The following is a description of a gene set: studied in species Homo sapiens Genes having at least one occurrence of the highly conserved motif M35 GCANCTGNY in the regions spanning 4 kb centered on their transcription starting sites. This matches the MYOD1 transcription factor binding site V$MYOD_Q6 (v7.4 TRANSFAC). from publication Xie X, Lu J, Kulbokas EJ, Golub TR, Mootha V, Lindblad-Toh K, Lander ES, Kellis M (PMID 15735639) Human Gene Set: GCANCTGNY_MYOD_Q6 Comprehensive identification of all functional elements encoded in the human genome is a fundamental need in biomedical research. Here, we present a comparative analysis of the human, mouse, rat and dog genomes to create a systematic catalogue of common regulatory motifs in promoters and 3' untranslated regions (3' UTRs). The promoter analysis yields 174 candidate motifs, including most previously known transcription-factor binding sites and 105 new motifs. The 3'-UTR analysis yields 106 motifs likely to be involved in post-transcriptional regulation. Nearly one-half are associated with microRNAs (miRNAs), leading to the discovery of many new miRNA genes and their likely target genes. Our results suggest that previous estimates of the number of human miRNA genes were low, and that miRNAs regulate at least 20% of human genes. The overall results provide a systematic view of gene regulation in the human, which will be refined as additional mammalian genomes become available., and this is the list of marker genes: ERP27, DOK7, NDUFB8, NRAS, DMPK, AGBL5, MLLT6, GATA2, TUBB2B, PCGF1, SYT6 (NCBI Gene Id 148281, synaptotagmin 6), CNFN, GALR1, LYL1, GUCY1A1, PDAP1, ANGPTL7, MYT1, ARHGAP36, CDK2AP2, RAB6A, MSS51, MXD4, SHISA7, L3MBTL2, SOX5, RUNX1T1, ELL3, CAMKV, CDH10, MYO19, CACNB1, SDHAF2, MBNL2, EXOC5, LNX1, ANP32A, USP54, CHRNE, MORC4, GRK5, CPSF7, ATP2A2, NTRK3, REPS2, TBCC, KIRREL2, CCDC148, RRAD, GPR37L1, YPEL1, TIGAR, POU2F1, CLDN15, XPO1, ATP5F1B, EGLN1, DES, GRHL3, IRX5, CAMK1D, CASK, HNRNPDL, RHBDF2, SLC9A7, NEURL1, ZMIZ1, MUSK, ETF1, KNCN, NEUROD1, S100A8, GGNBP2, SPINK5, SOX2, CSNK2A2, CD72, NRXN2, TBL1Y, ALK, CASKIN2, PLPP7, OXR1, NHSL2, COBL, BNC2 (NCBI Gene Id 54796), YWHAE, HSD3B7, GAPDH, SPATC1L, AMMECR1, NOL9, FRMD4A, SLC29A4, CACNA2D3, NKAIN2, VWA5A, PHACTR3, ATXN7L2, CYLD, FBLIM1, GFRA1, TPM2, CCNE2, PEG10 (paternally expressed 10), TXLNG, TPMT, IGFBP5, IKZF2, EHD1, PRKCB, WNK2 (NCBI Gene Id 65268), CADPS, LDB1, NR4A2, ENPP5, TNFRSF21, HLA-DRB5, NEDD4L, TNMD, SMAP2, NLGN2, SUPT16H, EGR2, LHX3, EZH2, ABCB9, HSPA5, HOXA2, LURAP1L, MYO18A, FA2H (fatty acid 2-hydroxylase), NEUROD6, PPP2R3A, HSP90AB1, TEAD2, DLL3, POFUT1, SH3BGRL3, MYCBP, POLD4, SEZ6, FITM1, OR2L13, HSALR1, ELAVL3, PLN, LAMA5, DRP2, NTN4, FSCN2, ZNF593, CHRD, UNC45B, DUSP4, LHFPL2, CD2AP (CD2 associated protein), TFAP2C, TJAP1, GIGYF2, DCHS2 (NCBI Gene Id 54798), KRT19, DMXL1, FGF12, TNNI2, HSPB6, PRR7, TRIM23, SLC43A3, ZMAT3, MAGI1, DAB2IP, SPEG, SYNRG, SNTB2, EFNA1, ITGB4, MORF4L2, CYFIP2, SOX15, FZD9, SRPK2, LRRN1, TSPAN9, DDIT4L, CDKN1B, EIF4G2, PTCHD1, PDE1A, ZNF503, RNF13, LDB3 (LIM domain binding 3), NOTCH1, CBFA2T3, ZFHX3, KLHDC7A, EDC4, KLHL41, ACTN3, KCNJ2, LINC01565, PPP2R5B, STRN3 (NCBI Gene Id 29971), MYCT1, TAS1R1, SIM2, ELP4, TNFRSF17 (NCBI Gene Id 608), RAPSN, TGIF1, SERF2, LRRTM3, E2F1, TEC, TRIR, RPS18 (NCBI Gene Id 6222), ITGB1BP2, BCAS4, STIM1, USP15, CRCT1, IGFBP3 (insulin like growth factor binding protein 3), XPO7 (NCBI Gene Id 23039), SPINT2, NAGLU, PPARGC1B, FOSL2, EML5, GABRA3, RNF19B (ring finger protein 19B), PDGFB, LORICRIN, NECTIN4, NPEPPS, CRIP2, KIF7, MEF2D, CLCN3, ANGPT1, MYL11, UBE2D3 (ubiquitin conjugating enzyme E2 D3), TMEM109, TACC1, IGFBP6, DBNDD1, NOL4, GATA3, ARMC8, ZNF205, GGN, ADAM11, PCDH12, AP5M1, STX5, SMARCA5, SPCS1, WNT6, KMT2E, SQLE, HOXD3, RNF220, SULT2B1, WDR47, JADE1, NDNF, CCDC177, VPS52, CAMKK1, KMT2A, CCND2, MCHR1, HTR2C, SREBF2, ZBTB16, RIN1, TSEN54, DNAJC17, CRELD1, HCRTR1, MT1E, GIT1, VAMP1, PCSK4, ODC1, HESX1, TJP1, PPP1CA, SYTL2, DNHD1, ZEB1, MLYCD, KCNQ1DN, ACVR1, PKP4, ELAVL2, FOS, AP4S1, PPP3CB, WWC1, CNTN6, TNNI1, COL4A3 (NCBI Gene Id 200750), SPEM1, TRAPPC13, GNG8, OVOL1, AARSD1, RBFOX1, HJV, METTL8, ADGRL3, EMX1, PCBP4, NGF, MRPS6, YPEL4, ROCK1, CITED2, FRMD6, CELF4, TMBIM1, EP300, DALRD3, CACNB3, NEFH, APOBEC2, HPCA, ADGRB2, ZBTB18, MPP2 (NCBI Gene Id 4355), SH3BP1, AXIN2, SZT2, FBXO32, ENO3, RXRG, TDRD5, MSANTD2 (Myb/SANT DNA binding domain containing 2), GPR162, ITPR3, AICDA, GFI1, BDNF, NEGR1, TNFRSF19, ALPK2, MAP3K5, LCN9, FABP3, KCNN3, ATP1A3, PELI2, BARX2, SCN3B, AARS2, TMEM184A, PRDM1, MYOM3, RYK (NCBI Gene Id 6259), PLEKHA6, NDUFAF3, TREX2, EPHB2, FYN, NEXN-AS1, TSC22D3, PURA (NCBI Gene Id 5813), TCF12, ADK, ZNF710, SOWAHA, IQSEC1, ATOH8, CDH13, NKX6-2, P3H3, FMR1, WBP1L, FGR, RBM15B, MTX1, JAKMIP2, COL7A1, ZMYM4, LEP, C22orf31, YWHAZ, RGS3 (regulator of G protein signaling 3), HOXA5, SPOP, NAPEPLD, SPG21, VEZF1, EIF4ENIF1, NUP88, SPTB, HSD11B2 (NCBI Gene Id 3291), LHX1, VEGFA (NCBI Gene Id 7422), LRMDA, EEF1A1, PLEKHH3, SMPX, LONRF3, ARHGEF12, TMEM178A, GFAP, ACTB, KLK1, SMARCA1, CUEDC1, PPP4R3B, KAZALD1, CLDN7, OGFOD2, CSDE1, SLC22A17, PCM1, RPAIN, LTB4R2, C11orf87, TAC4, CLDN9, STT3A, PACSIN3, DCAF1, SOHLH2 (spermatogenesis and oogenesis specific basic helix-loop-helix 2), FCGBP, HMGN2P46, CLDN3, TUFT1, CCDC85B, GRIK3, COL4A4, DLL1, ELAVL4, WBP2NL, RAB5B, HIRA, GRIN2D, GRK6, KIF1B, RADIL, ARHGEF6, PLEKHA4, OPCML, CLIP1, TMC3, LCE5A (late cornified envelope 5A), VPREB1, CXCL14, LIMA1, MOSPD1, RARA, ARFGEF1, ZNF521, NEBL, PBRM1, SCN8A, NRGN, PICALM, FLRT3, VDR, MPPED2, ADRB1, KCNQ5 (NCBI Gene Id 56479), GATA1, SHISA4, NBEAL1, ISL1, SYNGR1, RBM26, HHEX, SLC12A5, PCDH9, MYPN, TAPBPL, GPR52, TUG1, COL12A1, RPA3, TACR1, GPD1, LGALS1, TUBB4A, PNMA1, THBS3, WDR25, MID2, RASGEF1A, HES6, PPARGC1A, SLC9A9, CALM3, LRAT, IMMP1L, MLIP, PPM1J, SLC44A2, TRPC4, SV2A, MEGF10, CNIH2, MYOT, RBM47, INSRR, ALDH1A1, TSPAN13, BMP6, KCND2, SLC25A5, DST, NDST4, SOBP, LINC02908, MPRIP, PSMD3, SERPINB7, SIPA1, MYH10, WIPI1, RGS12, SLIT2, TNNC2, KCNS3, IL34, MIR22HG, PGM5, SURF4, RTKN, ENTREP3, MYO1E, HOXA7, TAOK1, SLC30A3, MAP1A, BEST3, ATP1B1, FCRLA, SOX14, LIPT2-AS1, SKIL, PCSK2, NEUROG2, CADM2, SSX2IP, NHLH2, KRT2, MASP1, MFNG, AKTIP, TPCN1, SLC27A2, TNFSF13, BCAS3, BAHD1 (bromo adjacent homology domain containing 1), EDA, GJA4, TMT1B, GAB2, LSR, LRRN3, NR2E1, COL22A1, PPP3CA, ITGA2 (NCBI Gene Id 3673), CLSTN3, SKIDA1, CHRNB1, GPD1L (NCBI Gene Id 23171), TRPV1, FGF17, PKD2L1, EPB41L4A, DMD, CCL27, SLC6A14, DGCR2, GMIP, PRMT3, FCMR, ZACN, PLCB3, CALM1, CTSG, C1QTNF2, ANKRD42, PSEN1, RFX1 (regulatory factor X1), ANKRD17, UBE2O, GRB7, SKP1, CD47, NOVA1, KANSL1L, ARL5B, DEPTOR, MYOZ3, PRICKLE1, MAGED1, HIVEP3, FAM107B, KRTCAP2, DENND1B, STAT5A, ADCY6, TRERF1, MMP15, IRF4, THPO, ARHGAP24, DVL3, DNM3, CYTH3, DPF3, PHLDB3, WDR81, LMO4, FNDC5, L1CAM (L1 cell adhesion molecule), STARD5, PPP1R17, GRIN2A, PRKACG, RASAL1, CSF1R, TRIM46, ANK2, NKX2-1 (NCBI Gene Id 7080), KLF13, AK9, LMAN2L, SLF2, GPR62, NBEA, MYH3, OTP (orthopedia homeobox), CLVS1 (clavesin 1), RORC, EDF1, ANXA8, SLC44A1, PAM, EIF4A2, IGF1R, SIX6, MFSD13A, RAB3A, FCRLB, RNF121, SLC25A10, ADRA2C, RBP5, RIT2, TGM1, KLK4 (NCBI Gene Id 9622), SLC8A3, FIG4, EYA1, GARIN1B, COL19A1, SLC7A8, FOXP2, MAP7, FUT8, PSIP1, HIF3A, ASB14, PPP4R4, ZFP91, ARID5A, APBB2, SOAT1, JPT1, BICDL1, CDK5R2, TBPL1, CPNE1, NR1H3, TDRKH, SGCG, GNL3LP1, PPP1R14C, MYC, DOC2A, RETNLB, ZNF367, HYAL2, PNPLA2, MRPL40, MYO7A, LMO3, SMTNL2, PCDH15, CD40LG, VSX2, PPP1R16B, IL17B, DLL4, PYY, IDH2, LARP1B, PIM2, UNC119, KCNQ1, TBL1X, KLHL40, B3GALT2, CELF3, WNT3, KLF12, SLC4A8, ANK1, C1GALT1C1 (NCBI Gene Id 29071), HDAC9, ABR, NNAT, USF1, HLA-DRB4, EPOR, BEX2, PER1, RBBP7, KCNIP3, EIF2B3, LRP5, NR2F2, NUMBL, LINC01567, COQ10A, CTAGE4, DLG2, BRINP1, HSD17B8, SVIL, KRT8, SYT4, DPYSL5, HSPA9, ERRFI1, PABPC5, ACSM6, SLCO4C1, NHLH1, LVRN, TGIF2, ST3GAL5, TFEB, KCNN2, DNMT3A, BNIP2, LINC00472, DOC2B, AUTS2, ZBTB25, PRDM13, C7, PNLIPRP2, SFTPC, CACNB2, LYPD1, TCF7, PCF11, PDE7A, SAMD10, KCNH2, FGFR1, PPM1A, CRB1, USP2, PHF21A, AQP5, NRK, SELPLG, PRKAG2, GPHN, TNKS2, RASD2 (NCBI Gene Id 57347), RTL3, PROX1, LEF1, TFAP4, BMPR2, GPR158, OSR1, MCAM, CDC42EP3, INHA, RSBN1, PARD3B, BCL7A, SOST, FCER1A, IGSF8, STXBP2, SLC37A1, ID1, MBNL1, CRLF1 (cytokine receptor like factor 1), NADK2, NCAM1, DCLK2, GSTT4, ACAP1, RPL4, KRT25, ERBB3, CDC42SE1, CNKSR2, HMGN2, ARHGAP8, NDUFA4L2, UBE2K, FNDC7, GPR173, ADAMTSL2, NRG1, PIGW, TRIB1, HOXA3, ASB15, SYT17, PTPRK, MED8, FGF13, BRD4, CCL20 (C-C motif chemokine ligand 20), LDLRAD3, TAFAZZIN, RUNDC1, TOR1AIP1, TTLL6, CLC, PTPRJ, NDUFA4, PLAGL2, PREX2, MYBPH (myosin binding protein H), SHOX2, XIRP1, DDIT4, CSMD3, RAB33A, SLC24A3, HDGF, HEYL, MLLT11, ZMYM2, LRFN5, HEBP1, PAX1, ADAM12, LRRC3B, ZSCAN25, VEGFB, NSG2, RNF213, GSK3B, ITGA7, ADAMTS8, ACTA1, CA7 (NCBI Gene Id 766), POMZP3, MPC2, STMN2, RALYL, RUNX1, PROSER3, RGS8, YTHDF2, HDAC11 (histone deacetylase 11), BAZ2A, TRIT1, LUC7L3, RTP1, MTUS1 (microtubule associated scaffold protein 1), FGF11, PCSK1N, BPTF, ATF7IP, SCFD1, GNB3 (NCBI Gene Id 2784), ZRANB1, TEF, ARL4C, RUFY1, C2CD2L, PLPPR1 (phospholipid phosphatase related 1), BRSK2, CABP1, ERLIN2, ZMYND8, IQCD, CDC73, PTH1R (NCBI Gene Id 5745), CIDEB, ROBO3, RRAGC, ZNF385A, MYH13, SLC25A41, DACT1, FAM53C, JAG1, ETV1, ENOX1, CDK2AP1, IPO13, GJA5, KIF13B, HLA-DRB1, SNPH, TMTC2, RASGEF1B, MANSC1, ERF, SYNE1, RABAC1, FGD2, HHATL, RAB7A, ADAMTS5, NRXN3, DCAF17, PSD, UNC13B, SPATA8, COL8A1, ASIC2, PRKCG, SYTL1, PKN1 (protein kinase N1), WNT10A, IRX4, RASSF2, CYSTM1